The following is a description of a gene set: from publication Myllykangas S, Himberg J, Böhling T, Nagy B, Hollmén J, Knuutila S (PMID 16751803) Human Gene Set: MYLLYKANGAS_AMPLIFICATION_HOT_SPOT_15 DNA copy number amplifications activate oncogenes and are hallmarks of nearly all advanced tumors. Amplified genes represent attractive targets for therapy, diagnostics and prognostics. To investigate DNA amplifications in different neoplasms, we performed a bibliomics survey using 838 published chromosomal comparative genomic hybridization studies and collected amplification data at chromosome band resolution from more than 4500 cases. Amplification profiles were determined for 73 distinct neoplasms. Neoplasms were clustered according to the amplification profiles, and frequently amplified chromosomal loci (amplification hot spots) were identified using computational modeling. To investigate the site specificity and mechanisms of gene amplifications, colocalization of amplification hot spots, cancer genes, fragile sites, virus integration sites and gene size cohorts were tested in a statistical framework. Amplification-based clustering demonstrated that cancers with similar etiology, cell-of-origin or topographical location have a tendency to obtain convergent amplification profiles. The identified amplification hot spots were colocalized with the known fragile sites, cancer genes and virus integration sites, but global statistical significance could not be ascertained. Large genes were significantly overrepresented on the fragile sites and the reported amplification hot spots. These findings indicate that amplifications are selected in the cancer tissue environment according to the qualitative traits and localization of cancer genes. studied in species Homo sapiens Amplification hot spot 15: colocalized fragile sites and cancer genes in the 6p25-p11.1 region., and this is the list of marker genes: FANCE, H4C9, IRF4, SRSF3, HMGA1, HSP90AB1, PIM1, TFEB, DEK, CCND3